The following is a description of a gene set: from publication Scheidereit C (PMID 17072322) species: Homo sapiens Transcription factors of the NF-kappaB family regulate hundreds of genes in the context of multiple important physiological and pathological processes. NF-kappaB activation depends on phosphorylation-induced proteolysis of inhibitory IkappaB molecules and NF-kappaB precursors by the ubiquitin-proteasome system. Most of the diverse signaling pathways that activate NF-kappaB converge on IkappaB kinases (IKK), which are essential for signal transmission. Many important details of the composition, regulation and biological function of IKK have been revealed in the last years. This review summarizes current aspects of structure and function of the regular stoichiometric components, the regulatory transient protein interactions of IKK and the mechanisms that contribute to its activation, deactivation and homeostasis. Both phosphorylation and ubiquitinatin (destructive as well as non-destructive) are crucial post-translational events in these processes. In addition to controlling induced IkappaB degradation in the cytoplasm and processing of the NF-kappaB precursor p100, nuclear IKK components have been found to act directly at the chromatin level of induced genes and to mediate responses to DNA damage. Finally, IKK is engaged in cross talk with other pathways and confers functions independently of NF-kappaB. Genes encoding IkappaB kinase (IKK) interacting proteins. Human Gene Set: SCHEIDEREIT_IKK_INTERACTING_PROTEINS, and this is the list of marker genes: CDC37, IRF7 (NCBI Gene Id 3665), BCL10, VAV1, EIF2AK2, CREBBP, MAP3K14, RIPK1, TRAF1, PDK1, IRS1, PRKCI, CASP8, ERC1, MAVS, HSPB2, STAP2, UBB, CYLD, NOTCH3, CCND1, TRAF3IP2, HSP90AA1, TRAPPC9, TANK, CTNNB1, DOK1, MAP3K8, CARD11, TNFAIP3, CSN3, ESR1 (estrogen receptor 1), MAP4K1, FKBP5, FOXO3, ATM, MAP3K3, HTT, NLRP2, TFG, RPS6KA1, NCOA3, CARD10, ZFAND5, FANCA, TRIM27, EPAS1, E2F1, ARRB1, RELA, MAP3K7, TRAF2, SCNN1B